The following is a description of a gene set: studied in species Homo sapiens Immune cell-specific expression is one indication of the importance of a gene's role in the immune response. In order to identify such patterns, we set out to broadly profile gene expression in a variety of immune cells. Genes up-regulated in comparison of unstimulated NK cells versus those stimulated with IL2 at 16 h. from publication Abbas AR, Baldwin D, Ma Y, Ouyang W, Gurney A, Martin F, Fong S, van Lookeren Campagne M, Godowski P, Williams PM, Chan AC, Clark HF (PMID 15789058) Human Gene Set: GSE22886_UNSTIM_VS_IL2_STIM_NKCELL_UP, and this is the list of marker genes: PRELID3A (NCBI Gene Id 10650), SIDT2, EXOC3, DSTYK, H2AC11, OSER1 (oxidative stress responsive serine rich 1), STAT6, ORM1, GZMK, TRIM10, GM2A, DYRK2, FRAT1, EFHC2, RPL30, KLRC4, N4BP2L2, APOM, ARIH2, SLC24A1, MXI1, FOXO3, ARHGAP12, SIDT1, TP53TG1, RPS12, ACTMAP, CDKN2D, ELANE, DLG2, ME3, NME8, S100A12, SLC1A7, RPS15A, OXLD1, FRAT2, AFF1, SDHA, RHBDF2, GCC2, TSC22D1, ZCCHC14, NACA, BTG1, ZER1, VIPAS39, METTL3, CAMK1D, RXRB, ZNF688, MED15, UBTD1, PDCD4, PLCG2, BSCL2, BTN3A3, APBB3, C14orf93, GPA33, SRSF5, CLCN6, SGSH, C2CD2, ST6GAL1, LRRC37A3, GNB5, BTN3A1, ZBP1, SDHAP1, CTSF, TASOR, ATM, CXCR4, POLL, CSTPP1, PCNT, ABCD4, PLEKHM1, LTF, IP6K2, VPS11, COQ8A, UBA7, TARBP1, TDRD3, MSL3, MYCBP2, IL10RA (NCBI Gene Id 3587), IGBP1, PTPRM, PSPC1, CIR1, UBE2B, AKAP8L, MICALL2, POLR1HASP, CASP9, HDAC5, CLEC2D, BAZ2A, MTMR3, SPINK2, MCOLN3, KRT18, PRDM4, SLC26A10P, NOP53, NCK2, CLDN15, CRACDL, APOBEC1, ANGPT1, PARP6, PAIP2B, CLCN7, DGLUCY, PAN2, NUMA1, AKAP13, TKFC, LMO1, KLHDC2 (NCBI Gene Id 23588), LMBR1L, CBFA2T3, NFATC1, CMKLR1, BTN3A2 (butyrophilin subfamily 3 member A2), TEKT2, RPS6KA2, MCHR1 (NCBI Gene Id 2847), YTHDC1, CHRM4, KDM3A, IRF3, VPS39, CITED2, SRSF8, RABGAP1, RSRP1, MED25, CRYBB1, FLT3, DUSP22, SUPT7L, SLC6A11, GAREM1, CTDSP2, CBX4, BTD, HSPBAP1, ATG2A, PBXIP1, TTN, OR2F1, HYI, ZNF226, ARHGAP25, DPEP2, NIPSNAP1, TYROBP, ZFTRAF1, CCS, PHF21A (NCBI Gene Id 51317), MKRN1, IZUMO4, PRKY, SLC35D2, WDR45, WDR48, NNMT, ZFYVE16, PIK3IP1, VPS9D1, KLF9, RPL13A, BSDC1, WDR33, ATXN1, SHOX2, SELENOP, FYB1, CCNG2, SIK3, YPEL1, RFX7, RNASET2, PTTG1IP, KIF1B, FAM8A1, KLHL3, SPSB3, BLTP1, MAN1B1, CHMP1B, LCN2